Given this list of marker genes Slc30a8, Exoc5 (NCBI Gene Id 218995), Exoc1, Ero1b, P4hb, Slc30a5, Exoc8, Exoc3, Exoc2, Ins1, Exoc4, Exoc7, here is a description of the gene set: studied in species Mus musculus Insulin processing Mouse Gene Set: REACTOME_INSULIN_PROCESSING